The following is a description of a gene set: species: Homo sapiens Human Gene Set: MIR452_5P Genes predicted to be targets of miRBase v22 microRNA hsa-miR-452-5p in miRDB v6.0 with MirTarget v4 prediction scores > 80 (high confidence targets). from publication Chen Y, Wang X (PMID 31504780), and this is the list of marker genes: UBE2D1 (ubiquitin conjugating enzyme E2 D1), DNAI7, KCNK2, PNN, GARNL3, SEC23A, TNPO1, GNPTG, KBTBD3, GABPA, SERTAD2, LINC03104, AFF4, CNOT11, SON, ARIH1, AKAP5, SRCIN1, TMED7, CCL23, ELAPOR2, PTPRR, PIP4P2, NFE2L3, CDK17, LAMC1, AGMO, VPS41, XKR6, UPF1, SCX, FILIP1L (filamin A interacting protein 1 like), ZDHHC21, GPR173, CTCFL, HAT1 (histone acetyltransferase 1), CREB5, ARHGEF10, BBX, NKX6-3 (NK6 homeobox 3), ALG2, ASCC1, RIC1, LIG4, SCAI, TES, DYRK1A (NCBI Gene Id 1859), SYPL2, CCNT2, PPP3CB, GALNS, RBFOX1, MKLN1, FGD4, CAPN7, SF3B1, PCGF3, MRPS23, EXOC4, SULF1, SERINC1, PAQR9, PGM2L1, PLAG1, GRM3, INTS8, LCP2, CASD1, ADAM22, FAM120A2P, MTMR6, ERI2, LIFR, DISC1, CRKL, TSPYL5, KCNH5, PHF6, RTP4, RNF139, SS18L1, GAN (gigaxonin), ARMC10, TYW5, TMEM87A, LINC03105, NPHP1, BICD2, SRD5A3 (NCBI Gene Id 79644), TNFSF13B, RORA, CDKN1B, RPA1, LEF1, VEZT, CD1E, PPA2, DISP2, GPR75, RPS6KA3, C14orf93, PTPRJ, RYK, FSD1L, TLL1, RPS16, DPY19L1, FAM8A1, CACNA2D1 (calcium voltage-gated channel auxiliary subunit alpha2delta 1), RAB42, BECN1, PDE10A (phosphodiesterase 10A), HORMAD1, BZW1, NPEPPS, SUPT6H, PKN2, PURA, ANKRD17, OIT3, SLC7A11, PIGK, CNTN3, TIMP3, ZNF692 (NCBI Gene Id 55657), GIN1, MAPRE1, ZNF621, XKR8, COMMD9, ERC2, STAM2, TENM1 (NCBI Gene Id 10405), SNAI2, ANAPC4, NFIB, BRDT, NOC3L, INKA2, ZNF644, CCNO, EMC8, RAB21, NDST3, HMGB3, SNRPD3, DSG3 (desmoglein 3), MAP3K20, TENT4B, YIPF6 (Yip1 domain family member 6), IGIP, DR1, KCTD15, EPS8, TIMP2 (NCBI Gene Id 7077), COLEC12, YWHAE, ELAVL4, SMAD4, AVL9, MBOAT2, DCLK1, TFAP2B, IMMP2L, EXOSC3, PPP1R10, TMEM232, DACT1, GSDME, BROX, ANKRD27, LXN, C3orf70, SP3, GJA1, HOMEZ, SEC63, TMOD2, ARF4, CHD2, ANK2, ZBTB20, APBA3, ENSG00000277067, ADD3, UBA6, SPRYD7, NCOA7, SMIM12, SNX18, RASGRP1, ANKS1B, PAN3, SLC27A6, JADE1, SUMO3, NAP1L5, CNPPD1, PRKAR2B, BDP1, WDR17, HP1BP3, GUF1, SOX7, RIMKLB, PLPP6, TTC21B, ZNF140, SIPA1L1, ESS2, SIAH1, HS3ST3B1, CEP350, SEC61A2, CTTNBP2, LRP1B, MZF1, C5orf24, PACSIN2